Given this list of marker genes MLST8, AKAP8L, NAPB, DDX50, CCR6, PLXND1, SYK, INO80E, CAPRIN2, TSPAN32, MYOD1, SPIC, SQOR, NLRX1, ADIPOR2, RGN, CSF1R, CDKN2B, LARP4B, ETFB, CASC3 (CASC3 exon junction complex subunit), NEDD8, PDE1B, ALG2, CWC22, SMARCC1, TGFB3, ING1, RRAS, ACOX1, AGAP1, HEXA, GLG1, ARRB1, PTCD2, DLX1, SIPA1L2, GGA2, MOS, PNKD, NAPSA, LPCAT1, BLK, FCER2, P2RX4, SFXN1, CLEC4A, RALY, FCF1, SEMA4B, SURF1, GABARAP, SMARCA4, SOX4, ANKH (ANKH inorganic pyrophosphate transport regulator), CD79B, PLD4, MEPCE, VAMP4, DNAJC11, GSTO1 (glutathione S-transferase omega 1), MARVELD1, NPM3, BRCA1, PDE8A, UBE2J2, PUM3, OGFOD2, CRIP1, F10, ZFP36L2, CTSB, GTF3C2, PSMD11, MRPL45, ETV1, PEA15, CNTN1, CTSD, SLC51A, CD93, ASPRV1, CD22, NOPCHAP1, ARID3B, NEURL4, GON4L, BAG3, TCF7, RBM38, TGFBI, NR1I3 (nuclear receptor subfamily 1 group I member 3), RGS14, ZFP28, HLA-DQA1, ITGB2, RCL1, GUSB, INSIG1, PLXNB2, FABP5, PSMD3, PLCG2, SIRPA, CD7, CCL22, TCEAL9, PPP1R21, MKLN1, RPAP3, EMP3, NPC1, PHC1, C22orf39, VIPR2, SLC44A2, GALNT1, EGR1, SLC7A7, LBP, ANGEL2, CBFA2T3, POLDIP3, SERPINB5, SLC44A1, EIF3B, G3BP1, SEPTIN9, ATP5MK, SLC7A5, EPHB6, ABHD14A, STRA6 (NCBI Gene Id 64220), TMEM150A, APOBEC1 (NCBI Gene Id 339), KLF7, DHX30, CX3CL1, TYROBP, MPO, UBAP2L, PLTP, PPP1R18, PRKCE, NUCB2, DNAJB2, RPS25, CCN4, TPP1, TCEA1, RPTN, PPFIA4, HUWE1, SGK1, LYL1, ITIH5, CTSH, ITPKB, ARHGAP1, VAMP8, ID3, CD14, VAMP2, DDX6, PAX1, FRRS1, SLC39A7, SURF4, AHNAK, SLC22A23, RAB20, UBXN8, PSMC5, RNF181, UBE2N, UBL4A, AIF1, CD72, ZIC1, TRAPPC10, PTPRE, CTSV, KAZALD1, TNFRSF1B, PER1, IDI1, NCDN, FGF18, PXK, OGDH, ENO3, RNF149, COLGALT1, CHTF8, IGLC7, DSTN, ERCC5, SLC9A8, GSTT2, CACNA2D3, here is a description of the gene set: studied in species Homo sapiens Human Gene Set: GSE3337_CTRL_VS_4H_IFNG_IN_CD8POS_DC_UP Although much is known on the transcriptional profiles of dendritic cells (DCs) during maturation, the molecular switches critical for the acquisition of a tolerogenic program by DCs are still obscure. In the present study, we explored the gene expression pattern of CD8+ DCs purified from the mouse spleen and treated with interferon (IFN)-gamma. The cytokine, indeed, potentiates the tolerogenic potential of this DC subset via induction of the immunosuppressive tryptophan catabolism mediated by indoleamine 2,3-dioxygenase (IDO). By comparing the expression of the IFN-gamma-modulated genes in IDO+ versus IDO- murine DCs, we found a consistent and selective association of the IDO-competent phenotype with the down-modulation of the Tyrobp gene, encoding the adapter molecule DAP12. IFN-gamma-mediated down-modulation of this gene involved IFN consensus sequence binding protein (ICSBP), a transcription factor also known as IRF-8. While silencing of Tyrobp conferred IDO functional competence on IDO- DCs, silencing of Icsbp1 in IDO+ cells completely abolished IDO expression and function. In parallel, silencing of TYROBP conferred IDO competence on human IDO- DCs while silencing of IRF8 impaired IDO expression and activity in human IDO+ DCs. Therefore, the same small set of molecular switches controls IDO competence in murine and human DCs. from publication Orabona C, Puccetti P, Vacca C, Bicciato S, Luchini A, Fallarino F, Bianchi R, Velardi E, Perruccio K, Velardi A, Bronte V, Fioretti MC, Grohmann U (PMID 16339401) Genes up-regulated in comparison of untreated CD8+ dendritic cells (DC) at 4 h versus those treated with IFNG at 4 h.